Given this list of marker genes Pramel53, Pramel47 (PRAME like 47), Zer1, Pramel34, Lrrc75a, Klhdc2, Pramel29, Klhdc3, Pramel55, Pramel48, Pramel28, Pramel14, Pramel42, Pramel37, Pramel39-ps, Zswim4, Pramel44, Pramel6, Pramel40, Pramel33, Klhdc10, Pramel43, Pramel11, Pramel57, Pramel27, Zyg11b, Asb4, Fem1c, Pramel18, Pramel17, Commd1, Pramel19, Zyg11a, Zswim8, Pramel36 (NCBI Gene Id 666089), Pramel49, Arih1, Pramel50, Pramel23 (PRAME like 23), Pramel32, Oog4, Pramel20, Pramel59, Pramel61, Pramel24, Glmn, Vhl (NCBI Gene Id 22346), Cul2, Pramel25, Pramel1, Pramel56, Pramel38, Pramel31, Oog2, Elob, Pramel12, Gm13040, Oog3, Zswim5, Pramel51, Fem1b, Pramel35, Fem1al, Rbx1, Zswim6, Pramel45, Pramel54, Appbp2, Pramel5, Pramel26, Pramel13, Pramel21, Pramel15, Rbx1-ps, Fem1a, Pramel30, Pramel41, Pramel60, Pramex1, Pramel22, Pramel16, Pramel46, Pramel7, Oog1, here is a description of the gene set: Mouse Gene Set: GOCC_CUL2_RING_UBIQUITIN_LIGASE_COMPLEX species: Mus musculus A ubiquitin ligase complex in which a cullin from the Cul2 subfamily and a RING domain protein form the catalytic core; substrate specificity is conferred by an elongin-BC adaptor and a SOCS/BC box protein.